Given this list of marker genes VMA21, POLG, SMN1, COL6A2, MEGF10, MLIP, SGCG, COL6A1, SGCA, ACTA1, BVES, DHX16, POPDC3, PHKA1, TWNK, here is a description of the gene set: Human Gene Set: HP_MUSCLE_FIBER_NECROSIS Muscle fiber necrosis Abnormal cell death involving muscle fibers usually associated with break in, or absence of, muscle surface fiber membrane and resulting in irreversible damage to muscle fibers. species: Homo sapiens